The following is a description of a gene set: species: Homo sapiens Mitochondrial gene expression Human Gene Set: WP_MITOCHONDRIAL_GENE_EXPRESSION, and this is the list of marker genes: TFAM, PPARGC1B, TFB1M, NRF1, MYEF2, PPARGC1A, GABPB1, POLRMT, CAMK4, MTERF3, HCFC1, GABPA, PPP3CA, PPRC1, SP1, CREB1, ESRRA, MTERF1 (NCBI Gene Id 7978), TFB2M